The following is a description of a gene set: Mouse Gene Set: GOBP_RESPONSE_TO_TRICHOSTATIN_A Any process that results in a change in state or activity of a cell or an organism (in terms of movement, secretion, enzyme production, gene expression, etc.) as a result of a trichostatin A stimulus. species: Mus musculus, and this is the list of marker genes: Hnf4a (NCBI Gene Id 15378), Hdac8, Mir208b, Ezh2, Mef2c, Hdac2